The following is a description of a gene set: General adaptation syndrome is the set of changes in various organ systems of the body, especially the pituitary-endocrine system, in response to a wide range of strong external stimuli, both physiological and psychological. It is described as having three stages: alarm reaction, where the body detects the external stimulus; adaptation, where the body engages defensive countermeasures against the stressor; and exhaustion, where the body begins to run out of defenses. Human Gene Set: GOBP_GENERAL_ADAPTATION_SYNDROME studied in species Homo sapiens, and this is the list of marker genes: HCN1, NR4A2, TMEM74, ZNF212, CRHR1, PENK